The following is a description of a gene set: studied in species Homo sapiens Human Gene Set: GOBP_DENDRITIC_SPINE_MORPHOGENESIS The process in which the anatomical structures of a dendritic spine are generated and organized. A dendritic spine is a protrusion from a dendrite and a specialized subcellular compartment involved in synaptic transmission., and this is the list of marker genes: EEF2K, CTNND2, EFNA1, DVL1, CDK5, HDAC6, LRRK2, PTEN, SHANK1, LRP8, PAFAH1B1, CDK5R1, SLC30A1, ARHGAP44, LZTS3, PAK3, DBN1, DOCK10, KIF1A, NLGN1, ABI3, CAPRIN2, RELN, SHANK3, SRCIN1, EPHB1, CDC42, ZDHHC15, NGEF, CUX2, WASL, ARC, EPHB2 (NCBI Gene Id 50980, EPH receptor B2), EPHB3, ZNF365, IL1RAPL1, DIP2A, CAPRIN1, PPFIA2, BAIAP2, STAU2, WNT7A, CAMK2B, ITPKA, ARHGAP33, SIPA1L1, PDLIM5, ABI2, DLG4, DHX36, GPRASP3, TANC2, ARMCX5-GPRASP2, EPHA4, PTPRD (protein tyrosine phosphatase receptor type D), CFL1, DTNBP1